The following is a description of a gene set: The establishment, maintenance and elaboration of the anterior/posterior axis. The anterior-posterior axis is defined by a line that runs from the head or mouth of an organism to the tail or opposite end of the organism. studied in species Homo sapiens Human Gene Set: GOBP_ANTERIOR_POSTERIOR_AXIS_SPECIFICATION, and this is the list of marker genes: WLS, LEFTY2, HEY2, ETS2, WNT8A, DDIT3, TBXT, OTX2, CER1, NRARP, RIPPLY2, SIX2, FRS2, TASOR, HOXD8, TDRD5, CDX1, PGAP1, TBX6, TDRD1, CDX4, PRICKLE1, CRIPTO, LEFTY1, TBX3, TMED2, WNT5A, GDF3, FOXA2, CTNNB1, TDRD7, TDRKH, EPB41L5, CDX2, NCKAP1, BASP1, SRF, SHH, NEUROG1, DCANP1, PCSK6, AURKA, TIFAB (TIFA inhibitor), BMP4, RIPPLY1, NODAL, LHX1, PLD6, TDRD6, SKI, MESP2, RNF2, MESP1, WNT3, GPC3, LDB1, SMAD4, WT1, ZIC3, FZD5 (NCBI Gene Id 81561)